Given this list of marker genes Dlx3, Fgf8, Enam, Kdm2a, Hes1, Nkx6-3, Gpat4, Wnt4, Sox11, Lef1, Cdh1 (NCBI Gene Id 12550), Dspp, Ros1, Rarg, Dicer1 (dicer 1, ribonuclease type III), Ascl5, Tyms, Mir875 (NCBI Gene Id 100124469), Gak, Foxj1, E2f4, Il6st, Bmp2, Bmp7, Dll1, Tmem231, Abl2, Cdkn1a, Spdef, Bhlha15, Clcn2, Smad2, Rara (NCBI Gene Id 19401), Fgf2, Plk4, Tlr9, Gata6, Abl1, Cep152, Gsdmc2, Fst (follistatin), Il31ra, Tgfb1, Emx1, Otp, Ipo7, Hoxa5, Sox9, Dmbt1, Fgfr3, Gcm2, Pou3f2, Insm1, Cdx2, B9d1, Lhx3, Wnt11 (wingless-type MMTV integration site family, member 11), Fam20c, Zfp800, Src, Cbfa2t2, Tubb5, Mcidas, Sav1, Nr5a2, Gata2, Wdr77, Dlg5, Foxa1, Mir203, Msx1, Tjp1, Ccno (cyclin O), Ttc8, Tmigd1, Mir7-2, Nfe2l1, Gata4, Trp73, Nfib, Map1b, Fzd5, Rptor, Gmnc, Ctnnb1, Yipf6, Deup1, Yap1, Serpine1, Mir7-1, Ntf5 (neurotrophin 5), Nodal, Onecut1, Tbx1, Sox4, Cebpb, Slc9a4, Afdn, Nkx3-2, Ptk6, Gja1, Vax1, Tigar, Pkp1, Xbp1, Rxra, Bccip, C1galt1, Ccdc78 (NCBI Gene Id 381146), Otx2, Prdm1, Rfx6, Ascl1, Kcnma1, Klf5, Rarb, Ift80, Gata5, Bmp4, Hif1a, Nkx2-2, Cav1, Cep63, Cdh2, Trp63 (transformation related protein 63), Shroom3 (shroom family member 3), Wdr72, Pgr, Ext1, Notch1, Fgfr2, Jag1, Pinc, Prox1, here is a description of the gene set: Mouse Gene Set: GOBP_COLUMNAR_CUBOIDAL_EPITHELIAL_CELL_DIFFERENTIATION The process in which a relatively unspecialized cell acquires specialized features of a columnar/cuboidal epithelial cell. A columnar/cuboidal epithelial cell is a cell usually found in a two dimensional sheet with a free surface. Columnar/cuboidal epithelial cells take on the shape of a column or cube. studied in species Mus musculus